The following is a description of a gene set: The oncogenic fusion protein, Pax3/FKHR, is a more potent transcription factor relative to its normal counterpart, Pax3. Since Pax3 induced a mesenchymal to epithelial transition (MET) in human SaOS-2 osteosarcomas, we hypothesized that Pax3/FKHR would also induce a morphological change in SaOS-2 cells. We demonstrate here that Pax3/FKHR more potently induces a MET in SaOS-2 cells than Pax3. This greater potency was further evident where Pax3/FKHR, but not Pax3, induced a morphological alteration in U2-OS osteosarcoma cells. By microarray analysis, we determined that Pax3/FKHR altered the expression of gene targets in a manner quantitatively and qualitatively distinct from Pax3. Three classes of genes were identified: (i) genes induced or repressed by Pax3 and Pax3/FKHR, (ii) genes induced or repressed by Pax3/FKHR but not Pax3 and (iii) genes induced by Pax3/FKHR but repressed by Pax3. Chromatin immunoprecipitations confirmed the direct binding of Pax3/FKHR to the promoter region of several factors including cannabinoid receptor-1, EPHA2 and EPHA4. Verification of the microarray data also revealed coordinate alteration in the expression of factors involved in BMP4 signalling. Regulation of gene expression by Pax3 and Pax3/FKHR is, however, cell-type specific. BMP4 expression, for example, was repressed by both Pax3 and Pax3/FKHR in SaOS-2 cells, while in the rhabdomyosarcoma, RD, Pax3/FKHR, but not Pax3, induced BMP4 expression. Thus, our data reveal that Pax3/FKHR regulates a distinct but overlapping set of genes relative to Pax3 and that the global set of Pax3 and Pax3/FKHR gene targets is cell-type specific. Genes down-regulated in SaOS-2 cells (osteosarcoma) upon expression of PAX3-FOXO1 fusion protein off an adenoviral vector. from publication Begum S, Emami N, Cheung A, Wilkins O, Der S, Hamel PA (PMID 15688035) Human Gene Set: BEGUM_TARGETS_OF_PAX3_FOXO1_FUSION_DN studied in species Homo sapiens, and this is the list of marker genes: SEMA3B, TIMP3, IL11, RREB1, MAFB, KCNG1, JAG2, DGKD, CARD10, VDR, ID1, SERPINE1, ITGA3, TPD52L1 (NCBI Gene Id 7164), SH3BP4, FLNB, AJAP1, BMP1, VEGFA, BMP4, MYC, EPHA2, GADD45B, THBS2, CFD, GCNT1, F2RL1, CD70, CPEB1, SOX9, TNC, ITGB4, PDLIM4, DKK3, BIN1, COL5A1, BCL2L1, WNT11, DHRS3, SMAD6, LBH, KLF10, KIT, STEAP3, EPHB2, TNFRSF12A